Given this list of marker genes UBL3, HERC1, ATP2B1, DCTN6, DDX6, IKZF5, IBA57, CNOT6L, COL6A2, ASB6, MIDN, NRIP3, ARFGEF2, SGK3, MLNR, ELL, SC5D, MAP3K2, EEIG1 (estrogen-induced osteoclastogenesis regulator 1), PTPRE, PDE4B, SMURF2 (SMAD specific E3 ubiquitin protein ligase 2), CFAP410, KDM6B, DNAJC3, MID2, POFUT2, FAM53B, DDR2, CRYBG1, USF3, CHD7, SERTAD1, PER1, RBMS2, REL, LONRF3, HCP5B, MMP9, MIA3, DNTTIP2, TGFB1 (NCBI Gene Id 7040, transforming growth factor beta 1), IL7R, ACSL1, ITGA5, BCL6, PTP4A1, BMAL1, CRTC2, HSPA13, SLC11A2, KLF3 (NCBI Gene Id 51274), RAB30, EPHA4 (NCBI Gene Id 401031), ARHGEF7, CACNA2D2, SMURF1, RB1CC1, PDP1, IFNGR1, ZBTB11, ALK, RNF38, MAP2K7, LYPD3, COG3, FGF9, MACO1, ZFP36, TNRC6A, OSBPL7, NOL4L, SNX30, CDK12, RAPGEF2, GNL1, ETV3, BACH2, RYK, CLCF1, SYAP1, TSC22D2, SMAGP, NBEAL2, ZFYVE28, LYZ, ZC3H12A, LINC00691, MLXIP, IER5L, CTRL, CHD1, DUSP10, DDI2, TSPYL2, ITPKB, GGA3, CHKA, CCDC93, RPS6KB1, PELI2, TOPORS, TRIM39, CXorf65, GPR65, NR1D2, DHX36, WDR91, DNMBP, ERO1B, RABGEF1, ZNF276, PHLDB3, KAT6A, REXO1, ZBTB10, HOOK1, ABCB1, MIDEAS, GALNT11, ITPRIP, ZRANB1, IDI1, RBM38, ANKRD13D, FAM210B, PIK3R1, TMEM88, BCOR, PLK3, CAMK2N1, IL18BP, LTBP4, FHIP1B, CARNS1, MXD4, RC3H1 (ring finger and CCCH-type domains 1), LUZP1, RINT1, NIPBL, SETD2, MSL2, CTSO, PSME4, FAM177A1 (family with sequence similarity 177 member A1), FBXO21, TBC1D23, MAPKAPK2, FAM83G, ZBTB2, KMT2D, GTF3C4, CYTH3, LINC00528, ENTPD4, SPON2, ENC1, EID3 (EP300 interacting inhibitor of differentiation 3), FOSB, BRD1, ATG2A, SFN, RNF125, AGFG1 (NCBI Gene Id 3267), KDM7A, EPC1, CRY2, STX1A, BAMBI, NFE2L2, TP53BP2, CKAP4, PIAS2, FOXO3, FBXL20, SMAD7, MIR101-1, TCF7L2, GPATCH8, TRIM52, YPEL5, SIRT1, DUSP2, C1orf115, OSBPL5, RSC1A1, PIK3CA, SPEN, BCL9L, ARID5A, PIK3IP1, CCNL2, here is a description of the gene set: Human Gene Set: GSE21063_CTRL_VS_ANTI_IGM_STIM_BCELL_NFATC1_KO_8H_UP Genes up-regulated in B lymphocytes with NFATC1 knockout: control versus stimulated by anti-IgM for 8h. Triggering of B cell receptors (BCR) induces a massive synthesis of NFATc1 in splenic B cells. By inactivating the Nfatc1 gene and re-expressing NFATc1 we show that NFATc1 levels are critical for the survival of splenic B cells upon BCR stimulation. NFATc1 ablation led to decreased BCR-induced Ca++ flux and proliferation of splenic B cells, increased apoptosis and suppressed germinal centre formation and immunoglobulin class switch by T cell-independent antigens. By controlling IL-10 synthesis in B cells, NFATc1 supported the proliferation and IL-2 synthesis of T cells in vitro and appeared to contribute to the mild clinical course of Experimental Autoimmune Encephalomyelitis in mice bearing NFATc1-/- B cells. These data indicate NFATc1 as a key factor controlling B cell function. from publication Bhattacharyya S, Deb J, Patra AK, Thuy Pham DA, Chen W, Vaeth M, Berberich-Siebelt F, Klein-Hessling S, Lamperti ED, Reifenberg K, Jellusova J, Schweizer A, Nitschke L, Leich E, Rosenwald A, Brunner C, Engelmann S, Bommhardt U, Avots A, Müller MR, Kondo E, Serfling E (PMID 21464221) studied in species Homo sapiens